The following is a description of a gene set: species: Homo sapiens from publication Travaglini KJ, Nabhan AN, Penland L, Sinha R, Gillich A, Sit RV, Chang S, Conley SD, Mori Y, Seita J, Berry GJ, Shrager JB, Metzger RJ, Kuo CS, Neff N, Weissman IL, Quake SR, Krasnow MA (PMID 33208946) Human Gene Set: TRAVAGLINI_LUNG_LIPOFIBROBLAST_CELL, and this is the list of marker genes: MAT2A, DEPTOR, TIMP1, CXCL12, PLSCR1, RDH10, FAM124A (NCBI Gene Id 220108), ERRFI1, OSR1, PROS1, ETF1, TUBA1C, CTH, UAP1, C7, SPTSSA, CD74, CEBPB, HAS1, ZFAND5, SOCS3, MIDN, IFITM1, EIF3J, TFPI2, HK2, SLC20A1, HOMER1, LONRF2 (LON peptidase N-terminal domain and ring finger 2), PLA2G2A, HAS2, GJA1, SERPINF1, PSMG1, CTSH, SGK1 (NCBI Gene Id 6446), SRPX, ABL1, COL1A1, MAFF (NCBI Gene Id 23764), PPP1R15B, NGFR, PIM1, PABPC4, ALDH1A3, SERPINE2, RND3, TIPARP, CYP26B1 (NCBI Gene Id 56603), WT1, ACSL4, GPRC5A, RARRES1, TYMP, MT2A, TWIST1, TRIB1, ATP13A3, MAPKAPK2, CREM, SPRY2, C3, PDLIM4, ELOVL5, KLF9, PLAUR, NCOA7, CDKN1A, MT1A, TBX18, UGDH, CDC42SE1, STAT3, LDLR, PLAAT4, GLI3, PVT1, NR4A3, ADAMTS4, TMSB10, CPXM1, OAF, REL, PHLDA1, APOD, ESYT2, B4GALT1, NNMT, PGAP1, MLLT11, C1S, CCDC80, GSPT1, DKC1, FGF7, THBS2 (NCBI Gene Id 7058), C1QTNF1, MARCKSL1, CYP1B1, TGIF1, CDON, KDM6B, MMP19, MRTO4, ZFP36L1, PITPNC1 (phosphatidylinositol transfer protein cytoplasmic 1), SEMA6A, PLIN2, NOP16, NGF, PNRC1, NIP7, TSHZ2, MCL1, COL3A1, SH3BP5, RGS4, PI15, KLF4, BNC2, GFPT2, DDX21, VEGFA, FOSL1, PDPN, SLC19A2, RGS2, NR4A2, IL1R1, PAPPA, PTPN1, KHDRBS3, RSPO3, GPNMB (NCBI Gene Id 10457), MEDAG, GATA6, SULF2, NFIL3, NAMPT, CCDC71L, MYC, IGFBP4, ELL2, FNDC4, CFI, CXCL2